Given this list of marker genes ABCB6, ABCG8, ABCG5, ABCB8, ABCA2, ABCD4, here is a description of the gene set: Human Gene Set: GOCC_ATP_BINDING_CASSETTE_ABC_TRANSPORTER_COMPLEX A complex for the transport of metabolites into and out of the cell, typically comprised of four domains; two membrane-associated domains and two ATP-binding domains at the intracellular face of the membrane, that form a central pore through the plasma membrane. Each of the four core domains may be encoded as a separate polypeptide or the domains can be fused in any one of a number of ways into multidomain polypeptides. In Bacteria and Archaebacteria, ABC transporters also include substrate binding proteins to bind substrate external to the cytoplasm and deliver it to the transporter. studied in species Homo sapiens